The following is a description of a gene set: Human Gene Set: PPARA_TARGET_GENES from publication Yevshin I, Sharipov R, Kolmykov S, Kondrakhin Y, Kolpakov F (PMID 30445619) Genes containing one or more binding sites for (PPARA) in their promoter regions (TSS -1000,+100 bp) as identified by GTRD version 20.06 ChIP-seq harmonization. studied in species Homo sapiens, and this is the list of marker genes: ERC1, ATP6V1F, GRK6, HECTD4, PAN2, RAB11A, HNMT, SLC9B1, IRAK4, LPCAT4, NME1, CARD8, STK11, CALU, TMEM268, POLR3G, TEF, SIRT6, NME1-NME2, ZNF622, CAPZA2, BCL2L13, ALKBH2, BICD1, OAZ2, NFIX, PAPLN, ARHGDIG, LINC03065, UBE2N, DANCR, RPS14, SPOPLP1, ZSCAN21, PEX1, ITFG2-AS1, GABPB1-AS1, TRPM7, CFAP68, TP53BP1 (NCBI Gene Id 7158), NAGLU, IL23A, KIF23-AS1, SLC25A3, ENSG00000213963 (novel transcript), ZNF770, MIR4449, A2M-AS1, KIAA1191, FANCD2, SAP30BP-AS1, DDX42, PPHLN1, PPIA, BICD1-AS1, NFE2L2, FCF1, NCKAP5L, HMGB3P22 (NCBI Gene Id 730702), CYP51A1, MIR4434, YAF2, CUL1, RBSN, SIK3, RBM18, RPL29P20, FDXACB1, DENND4A, CAPRIN2, TEAD1